Given this list of marker genes EXD2, APEX2, APEX1, MEIOB, REXO2, RAD9A, TATDN1, TREX1, POLE, POLD1, MRE11, POLG, RAD1 (NCBI Gene Id 5810), ISG20, TREX2, EXO5, here is a description of the gene set: Catalysis of the sequential cleavage of mononucleotides from a free 3' terminus of a DNA molecule. Human Gene Set: GOMF_3_5_DNA_EXONUCLEASE_ACTIVITY studied in species Homo sapiens